The following is a description of a gene set: studied in species Mus musculus Cell-cell signaling between presynapse and postsynapse, via the release and reception of lipid molecules, that modulates the synaptic transmission properties of the synapse. Mouse Gene Set: GOBP_TRANS_SYNAPTIC_SIGNALING_BY_LIPID_MODULATING_SYNAPTIC_TRANSMISSION, and this is the list of marker genes: Grm5, Pak1, Faah, Cnr2, F2r, Nrxn1, Cnrip1